The following is a description of a gene set: species: Homo sapiens The plasma membrane fusion process that results in fusion of mononuclear osteoclasts to form a multinuclear osteoclast. Human Gene Set: GOBP_OSTEOCLAST_FUSION, and this is the list of marker genes: DCSTAMP, SBNO2, CD81, CD109, TCTA, SH3PXD2A